Given this list of marker genes MIR128-1, RABGEF1, NBL1 (NBL1, DAN family BMP antagonist), APOD, NF1, C5, GREM1, CD200, CD69, MIR24-1 (microRNA 24-1), DDT, CYP19A1, MMP28, PLCB1, KLRK1, LRCH1, ADORA1, C5AR2, MIF, GCSAM, BCR, HMOX1, CCL21, IL33, CXCL12, SLAMF8 (SLAM family member 8), MIA3, DPP4, CCL2, DUSP1, GPR18, GDF15, MICOS10-NBL1, WASL, IL27RA, ADA, BMP5, HOXA7, CD200R1, RIPOR2, PTGER4, STAP1 (NCBI Gene Id 26228), SLIT2, CD300A, MIR146A, EMILIN1, CCN3, MIR223, CNN2, ADTRP, CCL25, TNFAIP6, CCL28, AKT1, PADI2, RIN3, KLRC4-KLRK1 (NCBI Gene Id 100528032), here is a description of the gene set: Any process that stops, prevents, or reduces the frequency, rate, or extent of leukocyte migration. studied in species Homo sapiens Human Gene Set: GOBP_NEGATIVE_REGULATION_OF_LEUKOCYTE_MIGRATION